The following is a description of a gene set: studied in species Mus musculus Mouse Gene Set: GOBP_NEGATIVE_REGULATION_OF_STRIATED_MUSCLE_CONTRACTION Any process that stops, prevents, or reduces the frequency, rate or extent of striated muscle contraction., and this is the list of marker genes: Bin1, Atp2a1, Arg2, Pde5a, Sri, Atp1a2, Adcy10, Grk2, Zc3h12a